Given this list of marker genes MMP12, THBS4, TRIO, NINJ1, KDM5C, PDXK, SEMA4D, DNM2, TRIP10, IER3, CD14, S100A1, POSTN, RAB31, S100A9, MGAT1, TBXAS1 (NCBI Gene Id 6916), HNF1A (NCBI Gene Id 6927), DHCR24, FN1, POMZP3, GRB7, C5AR1, PPIB, CDK10, LGMN (NCBI Gene Id 5641), NNMT, IFI27, PLOD1, TLR1, IL2RB, ATP1B1, LPCAT3, EDC4, GNA15, SOD2, SUPT5H, CDH11, CCR1, SECTM1, PLD3, NRG1, SPI1, DEFA1, CYP27A1, TAX1BP3, PRRX1, ETS1, PIEZO1, DNTT, FZD2, AGXT, MT1H, TARBP2, LTF, MAN2B1, AOAH, MYLK, MYL9, DUSP2, LGALS3BP, LAG3, EYA2, MT2A, FOXM1, GDF15, ORM1, DOK1, COL1A2, WASF3, C3AR1, SAA1, P2RX4, here is a description of the gene set: studied in species Homo sapiens Genes in the cancer module 241. Human Gene Set: MODULE_241